Given this list of marker genes Tmc5, Herc1, Lrit1, Scai (NCBI Gene Id 99056), Dmxl2, Ociad1, Cttnbp2, Nos1, A830018L16Rik, Cts6, Slco5a1, Gask1b, Fscb, Lsm6, Nmrk1 (nicotinamide riboside kinase 1), Sult1d1, Abhd11, Epc2, Col5a2, Ust, Grpel2, Casp12, Fam199x, Utp6, Arid1a (NCBI Gene Id 93760), Bcl2a1d, Dclk1, Kcnb2, Tmem123, Necab1, Grem1 (NCBI Gene Id 23892), Zhx1, Cnot2, Map3k2, Far1, Zmynd11, Chmp5, Rraga, Myo1c, Myog, Fbxo33, Otud1, B3gnt5, Rhbdl1, Plac1 (NCBI Gene Id 56096), Serpina3a, Smad4, Tbx15, Nars1, Vdac2, Gprasp2, Pax3, Pcdh18, Adgrb3, Nkd1, Vrk1, Fmn2, Ano3, Slc10a2, Cox17, Rb1cc1, Htr2a, Togaram1, Fgf7, Slc38a2, Fut4, Elapor2, Lrrc74b, Bnip2, Jak2, Nufip2, Aopep, Zfp710, Bicd1, Hpcal4, Dbf4, Slc41a2, Tent5d, Tc2n, Rbm26, Vps37a, Sfi1, Pdlim5, Clip1, Sdf2, Plekha3, Rbm27, Lair1, Poc1b, Marchf7, Zxdb, Ms4a2, Hook3, Mmp9, Smim17, Tceal8, Mycs, Tslp (NCBI Gene Id 53603), Serpina6 (serine (or cysteine) peptidase inhibitor, clade A, member 6), Bloc1s6, Efl1, Zfp423 (NCBI Gene Id 94187), Cript, Kcne2, Zfp994, Pik3ca, Brinp3, Cyp26a1, Pcdh11x, Sec24c, Myb, Zfp62, Ttc21b, Gucy1a2, Dach2 (NCBI Gene Id 93837), Nup98 (nucleoporin 98), Dclk3, Zfp280d, Gm4952, Prl5a1, Tcf7l2, Syt16, Zfp704, Ebf2 (NCBI Gene Id 13592), Zfp945, Pdss2, Rad18, Dmgdh, Med12, Picalm, Fbxo32, Acvr2a, St8sia2, Ube2d3, Mal2, Sema3c, Lcorl, Rreb1, Fut9, Bcor, Selenof, Vps26c, Sec14l2, Pde7a, Mfhas1, Tshz3, Ccdc81, G2e3, Nol3, Hnrnpdl, Qser1, Med14, Ncs1, Ino80d, Mospd2, Zswim2, Nopchap1, Ddr2, Snap25, Utp15, Calb1, Bmpr2, Rpp30, Rad51d, Kcnk1, Hapln1, Samd4b, Vps13a, Uri1, Irf2, Acta2, Bcl2a1b, Ppp1r26, Tada2b (NCBI Gene Id 277862), Svip, Kcnk2, Col4a4, Stt3a, Ythdc2, Slc35f3, Mrpl50 (mitochondrial ribosomal protein L50), Tll1, Trim8, Lpar4, Akap11, Zfp735 (zinc finger protein 735), Kcmf1, Lcmt2, Rbm11, Slc1a2, Plekhb1, Pter (phosphotriesterase related), Gpr141, Spsb4, Elp1, Tceal7, Bcl2a1a, Nlgn1, Nqo1 (NAD(P)H dehydrogenase, quinone 1), Otulinl, Tet2, Rbm24, Slc25a40, Vash1 (NCBI Gene Id 263410), Ube3a, Marchf2, Erp44, Armcx3, Ythdf3, Rpn1, Erbb4, Wasf1, Zfhx3, Ado (2-aminoethanethiol dioxygenase), Itgal, Chek1 (checkpoint kinase 1), Galntl6, Enox2, Ryk, Steap2, Ncapd2, Gatb, Ro60, Sema6a, Gphn, Cmtm4, Lamp5, Jcad (NCBI Gene Id 68804), Rhot1, Pard3, Lpp, Pcdhb22, Gabrg1, Fbxo4, Stk32a, Golim4, Tfg, Bub1, Raver2, Slc5a7, Kmt2a, Eya1, Elmod1, Shb, here is a description of the gene set: studied in species Mus musculus Mouse Gene Set: MIR_664_3P Genes predicted to be targets of miRBase v22 microRNA mmu_miR_664_3p in miRDB v6.0 with MirTarget v4 prediction scores > 80 (high confidence targets). from publication Chen Y, Wang X (PMID 31504780)